The following is a description of a gene set: species: Homo sapiens Mitochondrial biogenesis Human Gene Set: REACTOME_MITOCHONDRIAL_BIOGENESIS, and this is the list of marker genes: ATP5PF, ATP5MF, TWNK, ATP5MC1, TGS1, HCFC1, SOD2, APOO, GABPB1, SIRT3, PERM1, CREBBP, ATP5PO, ATP5MK, POLG2, NCOR1, ATF2, MEF2C, CALM1, DNAJC11, SIRT5, SMARCD3, ATP5PB, PRKAB2, ATP5MJ, ALAS1, SIRT4, MAPK12 (NCBI Gene Id 6300), CREB1, CYCS, ATP5ME, TBL1XR1, MICOS10, CAMK4, MTX1, IMMT, CARM1, CRTC1, GLUD1, CHD9, ATP5F1B, MT-ATP6, ATP5MG, TFB1M, ATP5F1A, TBL1X, PRKAA2, CHCHD6, SSBP1, PRKAG1, TFAM, NCOA6, CRTC2, ATP5F1C, RXRA, MTX2, NR1D1, ATP5MC3, MICOS13, MT-ATP8, USP46, SAMM50, MTERF1, ATP5MC2, TFB2M, HELZ2 (helicase with zinc finger 2), HSPA9, CRTC3, ATP5PD, TMEM11, PRKAG2, PPRC1 (NCBI Gene Id 23082), MED1, PRKAB1, PPARGC1A, ATP5F1D, NRF1, NCOA1, ESRRA, ATP5F1E, MAPK14, ACSS2, HDAC3, MAPK11, CHCHD3, PPARGC1B, APOOL, PRKAG3, DMAC2L, GLUD2 (glutamate dehydrogenase 2), IDH2, POLRMT, PPARA (NCBI Gene Id 84730), GABPA, MEF2D, NCOA2